The following is a description of a gene set: from publication Yevshin I, Sharipov R, Kolmykov S, Kondrakhin Y, Kolpakov F (PMID 30445619) Human Gene Set: ZNF816_TARGET_GENES Genes containing one or more binding sites for (ZNF816) in their promoter regions (TSS -1000,+100 bp) as identified by GTRD version 20.06 ChIP-seq harmonization. studied in species Homo sapiens, and this is the list of marker genes: PSMD12P1, CHCHD5, STAG2-AS1, RECQL5, ZNF564, NUDT21, DEDD2, RAB30-DT, FIS1, MT-TT, STAT3, ANKRD13A (ankyrin repeat domain 13A), ARHGAP40, B4GAT1-DT, GPR180, WDR24, C12orf76, C1orf159, MRPL54, FAAP24, UTP3, UFSP2, FBXL19, KCND1, LINC02918, ZNF846, HSDL1, NME1, COX16, PDE6D (NCBI Gene Id 5147), RBBP5, VTRNA1-2, GNAL, TIMM22, INTS14, MYO15B, POC5, IL6R, SAMD9 (sterile alpha motif domain containing 9), LINC01409, SLC6A6, WEE2-AS1, POP4, BMP7, IFNAR1, EMG1, CD81, KDSR, SMG7, DYNC2I2, LSG1, B4GAT1, NUP107-DT (NCBI Gene Id 100507250), ZDHHC18, ALOX12B, UPF1, ZNF766 (zinc finger protein 766), KIAA0232, NPLOC4, DUSP5-DT, DHDDS, PAFAH2, PRKCH, SMARCD2, MTCO3P12, MAK, NUP107, EIF4E, MRPL44, RNVU1-15, TAPT1-AS1, TLE2, PLPP1 (NCBI Gene Id 94702), CYP39A1, KLHDC9, ECI1, ZNF791, DSTYK, WDR62, CUEDC2, RTEL1-TNFRSF6B, XRCC6P1, LRP3, TTI2, SERAC1, SAMD3, OSGIN1, LINC02810, SUPT7L, TRAF4, LRRC40, STK16, APC, PELI2, TRAF5, MAFK, ALKBH6, BANF1, OGFOD1, HSPB6, KCNK1, FIRRE, TUBGCP2, MIR1302-3, VMP1, HLA-A, ZNF524, ZNF233, CCDC78, GCAT, STIM2, PGM2L1, SLX9, MIR6762, MCF2L, HLCS (NCBI Gene Id 3141), MTND5P11, SLC35G2, ATP13A4, TEFM, EDRF1-DT, PTCD1, MAPK12, NXPH3, PSMA3, LTBP4, VPS33B, PLK3, SMG5, SESTD1, SEC16B, SAR1B, ZNF461, DPF1, TRABD-AS1, WDR36, CCSER2, MT-ND6, CDK5RAP1, NOTCH1, BDKRB2, SYTL3, FZD6, NIFK-AS1, CPSF4, EIF1AD (NCBI Gene Id 84285), TIMM29, MTF2 (metal response element binding transcription factor 2), MED23, CBX4, SMARCD1 (NCBI Gene Id 6602), TTC29, DNM2, NDUFAF1, TRDMT1, ASXL1, COP1-DT, IFT56, NELL2, SLC24A1, DPP9, WDR11-DT, REXO4, WDR31, SMG7-AS1, ZMYND19, TFEB, SIPA1L3, CLUAP1, RFX5, CCBE1, BMS1, CARS1, COPS2, PROSER3, SPNS1 (NCBI Gene Id 83985), LINC00339, TM4SF19-AS1, MXI1 (MAX interactor 1, dimerization protein), ALKBH3, NME1-NME2, RGS20, MICU1, CFAP96, GBA1, COPS7B, RHOF (NCBI Gene Id 54509), REEP1, HYAL2, SLC4A1AP (solute carrier family 4 member 1 adaptor protein), LINC01623, SRRM2, HUWE1, PCDHGC3, POLR3B, DZANK1, MICALL2-DT, ICA1L, CFAP74, CRAMP1, ADRA1A, CABP5, RNU5E-4P, ROPN1L-AS1, TMEM242, RPL27, LTA4H, SDCBP2, IPO4, ZNF511, DET1, SUOX, EFCAB7, COX6A1, RNA5SP362, MYO18A, PKIG, VPS25, RFX1, PRKG1-AS1, SHLD2P1, BRINP2, MIR1289-1, AURKAIP1, VWA3B, CFAP45, PCDH12, PIH1D1 (NCBI Gene Id 55011), WDR59, XRCC1, CCDC77, TMEM200A (transmembrane protein 200A), C1orf210 (chromosome 1 open reading frame 210), ZNF569, RPSAP69, KLHL22, PRDX3, SHROOM3, RC3H2, BET1L, UBOX5, MCRIP2, DERL2, SAMD4B, MBL1P, HECTD2, MFAP4, MTR, ROPN1L, ZNF286B, PDE4A, SPEF2, ENSG00000232995, STRIP1, FAM53C, EEF1A1P23, DHRS4-AS1, HAGHL, CREM, SMG8, C8orf48, PIGV, SSBP1, APOA1-AS, PSMD12, BPNT1, WDR70, EXOSC8, HIKESHI, PYURF, ZNF131, ZNF566, MRPS31P5, LCP2, ADPRS, JPX, ENSG00000249295, HEXA-AS1, CTSH, HEXA, NDUFB7, VPS33B-DT, LRP5, MARK2, EFCAB5, OPA1, SLAMF6P1, BTG1, RTEL1, CBX7, ZNF391, TOB2P1, B4GALT5, APAF1, METTL26, CCNI, TOP3B (NCBI Gene Id 8940), TRIM41, ALG10B, ZNF286A-TBC1D26, PLAT (plasminogen activator, tissue type), GTF2H4, FLT4, MT-TE, CFAP298, TMEM242-DT, ITGB7, STX16, CSTPP1, MRPL40, FBXO34-AS1, MIR4736, MED24, INTS12, MRPL53, ZNF568, MNAT1, MIR4674, CEP250, SF3A3, GEM, CCDC159, VTA1, ZNF529, PDE8A, TAPT1, CFAP298-TCP10L, ZNF627, GNE, STIM2-AS1, RPS13, LINC01089, ZNF609, HES2, IDE, CEP89, MIR5087, TBC1D19, HIRA, DHX8, CILK1 (NCBI Gene Id 51541), C18orf21P1, FLVCR2-AS1, RNVU1-34, FGD4, GTPBP3, DUSP14, ZNF383, NBR2, GLI1, PDK1, RHEBP1, GIN1, TOR1AIP1, COP1, EGLN2, LINC02136, RAB30, UQCC1, FEM1A, STMN3, GORASP2, SUPT3H, DPY19L2P2, VPS51, SLC12A2-DT, TLCD3B, KSR2, CD320, MTMR9, UTP11, NALT1, PDLIM2, LINC02695, AHNAK, ZNF629, HS3ST3B1, STAG2, MAPK8IP3, GALK2, TMEM132A, RPS7 (ribosomal protein S7), ALPK2, ANKRD40, ENSG00000263080, THSD1, FAN1, LINC02643, ZNF286A, CLASP1, TMEM79, PHF21A, TRIM38, RCAN1, TPST2, OTULIN, HSCB, CFAP69, DGAT1, GSTCD, FBXO34, ZNF570, SRSF11, FIZ1 (FLT3 interacting zinc finger 1), SLC23A2, FGFR1, HAPLN1, MIPOL1 (mirror-image polydactyly 1), KDM5A, MCM3AP, LINC01547, TBX18, PDE1B, SEMA4D, TAF2, IPO13, CACNA1I, SYNJ2BP-COX16, GRHPR, COMMD4, ENPP3, SUPT5H, RIC8A, RAET1G, WDR11, LINC01775, IRF5P1, YBEY, FRMD4A, FLRT3, DNAAF1, ZNF282, DMAP1, OTULIN-DT, ALOX12P2, LINC01635, RTN4, LINC01139, LINC02965, ZNF790, RASL11A, TIPRL, NUP50, DRG2, RHEB, BAALC-AS1, TTPAL, PIGM, KMT2B, TACO1, SLC22A7, ZNF221, ZNF511-PRAP1, DAD1, LYPD1 (LY6/PLAUR domain containing 1), ADRM1 (NCBI Gene Id 11047), PHB2, YIPF2, ALDOA, STRN3, NR3C1, VTRNA1-3, TAP2, ANXA2R, ZNF490, PLCXD1, CAMK2N1 (calcium/calmodulin dependent protein kinase II inhibitor 1), ZNF345, STX16-NPEPL1, AQP4, EVI5L, LAMB2, SLC33A1, MIR548AL, GLB1L, IFT140, NDUFS7, C17orf75, FAT3, MIR1273C, TMEM168, GDF5, RPL6, FRA10AC1, EHMT1, FASTKD5, POLR2J3, SHOX2, RRAS, SNRNP27, RNVU1-21, HECTD1, SRCIN1, NKAPP1, BRCA1, RPLP0P2, TRIP4, MAN1C1, BAZ1B, DAPK2, NUF2, TBC1D1, MBD2, NDUFAF4P1, CCNC, DPY19L2P1, PINLYP, KCNH3, IRAG2, ADAP2, PCLAF, CALM1, WIPI2, TRPM6, RHEBP2, ITGB3BP, MIS12, UNC119, RPL23A, SVIL, MED14, MIR638, BRF2, SYNJ2BP, RAB34, MIR4638, TMEM45A, CHEK2, SRRT, SLC35B2, PLEKHG5, RPL37, VARS2, NXF1, ZNF829, TARS2, AARS2, STK32B, SETD1B, RGS5, DHRS12, ANO8, NFKBIA, BTG1-DT (BTG1 divergent transcript), HERC3, EOLA2-DT, ACYP2, INSYN1-AS1, C6orf226 (chromosome 6 open reading frame 226), ALG5, PPIP5K2